The following is a description of a gene set: Human Gene Set: HP_ABNORMAL_CIRCULATING_LEPTIN_CONCENTRATION An abnormal concentration of leptin in the blood. species: Homo sapiens Abnormal circulating leptin concentration, and this is the list of marker genes: LEP, BANF1, BSCL2, CIDEC, LMNA, AKT2, KCNJ6, LIPE, ADCY3, LEPR, ZMPSTE24, MECP2, AGPAT2